The following is a description of a gene set: Mouse Gene Set: GOBP_DETECTION_OF_TEMPERATURE_STIMULUS_INVOLVED_IN_SENSORY_PERCEPTION_OF_PAIN studied in species Mus musculus The series of events involved in the perception of pain in which a temperature stimulus is received and converted into a molecular signal., and this is the list of marker genes: Pawr, Adora1, Ano1, Tac1, Disc1 (disrupted in schizophrenia 1), Scn9a, Asic3, Cxcl12, Lxn, Comt, Scn10a, Htr2a, Mmp24, Cxcr4, Trpv1, Scn11a, Tac4, Tlr4, Nr2f6, Ephb1, Arrb2, Prdm12 (NCBI Gene Id 638804), Calca, Nrg1, Ntrk1, Scrn3, Ntsr1